The following is a description of a gene set: An abnormality of the urinary bladder. Human Gene Set: HP_ABNORMALITY_OF_THE_BLADDER studied in species Homo sapiens Abnormality of the bladder, and this is the list of marker genes: PSAP (prosaposin), GABRG2, GBE1, SYNE1, PIK3R5, CISD2, ACBD6, PDGFB, EPHB4, DNMT1, EIF4H, UBAP1, HNRNPK, SLC25A4, ZC4H2, CEP135, CHRNA2, POLG, ATXN3, ROBO1, NOTCH3, UFC1, PAX6, IFT74, EXT1 (exostosin glycosyltransferase 1), SDHD, RPL11, GJA1, DEPDC5, GALNT2, SLC35A2, CHRM3, RAC2, BBS5, MTMR14, NSD1, MAPKAPK5 (NCBI Gene Id 8550), ITGB4 (NCBI Gene Id 3691), SDHAF1, CHD4, TBP, DARS2, ATRX, BBS4 (Bardet-Biedl syndrome 4), KMT2D, HNRNPA2B1, KMT2C, NIPBL, LTBP4, SPG7, CHRNB2, KCNC3, PIGO, GTF2IRD1, BBIP1, CC2D2A, HOGA1, SMC1A, DMPK, STK11, SIX1, LIMK1, SIX5, MYLK, TP63 (tumor protein p63), TGFB1, RBM8A (RNA binding motif protein 8A), STAMBP, ERCC8, SPART, SHANK3, CCND1, CENPE (NCBI Gene Id 1062), LRRK2, LAMA3, GREB1L, SPAST, COG7, CTSH, FLVCR1, SASS6, TPP1, RETREG1 (reticulophagy regulator 1), GATA3, RARB (NCBI Gene Id 5915), RRM2B, BMP1, WWOX, ELN, HMBS, MARS2, ARNT2, SALL1, VANGL1, IFT57, HPSE2, ATL1, CFAP418, MYH11, TNFSF4, PRNP, UNC45A, CCL2, LAMC2, MFSD2A, FARS2, PANK2, METTL5, PAX2, DSE, JRK, ARL6, ATXN2, MCPH1, HACE1, VCP, MYRF, DNAJC13, FBXO7, CAPN1, NBN, IGHMBP2, PBX1, DKK1, PPOX, DNMT3A, VANGL2, SPG11 (NCBI Gene Id 80208), WNT7B, PDGFRB, SMAD3, PLXNA1, KCNT1, ZFYVE26, BBS9, IFT27, FKBP6, SCLT1, ADH1C, WFS1 (wolframin ER transmembrane glycoprotein), ZEB2 (NCBI Gene Id 9839), MAPT, CHMP2B, MCM7, COPB1, TRAF7, AP5Z1, AQP2, TRAPPC12, PUF60, ALS2, COMT, CFAP43, SEC24C, COL18A1, COL5A1, PIGA, AKT1, IFT172, KIF1A, BAP1 (BRCA1 associated deubiquitinase 1), PHC1, TTR, NF2, HSPA9, MTFMT, NEFL, ATXN10, B4GALNT1, GNB1, CIT, DNAJC30, CLIP2, SLC1A4, RBCK1, NDUFB8, KIFBP, FA2H, COL3A1, SNCA (synuclein alpha), TRPV4, PNPT1, SACS, KNL1, TRIM32, DACT1, CRH, CARMIL2, CHRNA3, DVL3, RTN2, IGF2, CDH11, TTPA, ITGA6, GIGYF2, NPHP3, TBCK, GNB2, ARX, FLNA, FAM20A, HNRNPU, HOXA13, FANCF, DSTYK, HES7, EBF3, SDHA, CPT1C, KPNA3, FUS, VPS37D, NPHP1, RYR1, STX1A, MED12, AVPR2, NAB2, CHST14, METTL27, KCNQ1, KCNQ1OT1, BBS7, MYOCD, KCNJ18, COL5A2, LAMB3, SMARCA2, SDHB, MPZ, BBS1, PPP3CA, SP110, PLOD1, FRMD5, MNX1, GABRA3, GPR101, CEP19, RNF170, SMARCE1, CCBE1, BUD23, SPOP, GRIP1, UPB1, CHCHD10, NR4A2, ERI1, ANKLE2, PRKAR1B, LZTFL1, SALL4, CEP63, ABCD1, SMO, PAH, CLCNKB, GTF2I, HLA-DQB1, ZMIZ1, HIRA, COL1A2, EFEMP2, FKBP14, CHRNA4, DBH, FMR1, SARS1, NEXMIF, LTBP1, P2RY11, COL1A1, RFC2, COL7A1, WDPCP, EIF4G1, LRIG2, KCNJ10, TTI1 (TELO2 interacting protein 1), FREM2 (FRAS1 related extracellular matrix 2), ALDH18A1, PEX11B, WASHC5, GGT1, TRPS1, AUH, EN1, SOX17, KIF5A, TBX1, BPTF, SF3B2, RALGAPA1, EIF2AK1, TERT, LMOD1, TRRAP, DPH2 (NCBI Gene Id 1802), AIP, TAF6, SBF1, ARVCF, SNCAIP, GBA2, FOXP1, EFEMP1, HLA-B, ARSA, SLC2A1, MYO1H, PAK2, COG5, LMNB1, PI4KA, GABRA1, KAT5, SLC12A3 (NCBI Gene Id 6559), KRAS, DDX6, NCAPD3, BICC1, TYROBP, ROBO2, EHMT1, CACNA1H, POT1, RAP1B, MAPKBP1, MAP3K7, ASPM, TIMM50, DPH1, CEP85L, EYA1, MBTPS2, HDAC8, MT-TT, TBL2, REEP1, KANSL1, KMT2B, PIK3CA, VPS11, CLCN6 (NCBI Gene Id 1185), SCAPER, TTC8 (tetratricopeptide repeat domain 8), POLG2, CCNQ, SMARCB1, NGF, REEP2, BRD4, MMP1, CHD7, STAT6, SUFU (SUFU negative regulator of hedgehog signaling), HAAO, FGF10, GAA, NCAPG2, CACNA1S (NCBI Gene Id 779), PLP1, NRIP1, TRAPPC10, AMFR, TWNK, CAMK2B, FOXP2, ATP7A, ZMYM2, KCND3, HCRT, CDKN1C, FANCI, POLR3A, JMJD1C, ADNP, PMP22, RREB1, MORC2, FGFR2, ATXN8OS, EIF2AK2, TBXT, EXT2, ASXL1, PINK1, APRT (NCBI Gene Id 353, adenine phosphoribosyltransferase), OTUD5, FOXF1 (forkhead box F1), NCF1, EP300, BAZ1B, ENSG00000288330, CDC45, MOG, MLXIPL, NKX2-1, CYP7B1, TBCD, FXN, AGXT, H4C9, PEX3, APC2, TAF13, TMEM270, SQSTM1, HLA-DRB1, CDK5RAP2, SLC9A6, RNF125, SLC25A13, JAG1, DLG3, ERLIN2, FGFR3, POR (NCBI Gene Id 96440), CACNA1G, DDHD2, CEP290, RASA1, SLC20A2, RAD21, SLC44A1, UBE2A, GJC2, POLRMT (NCBI Gene Id 5442), PYCR2, PSMD12, CEP152, GABRB3, SPTLC1, DNM2, MYL9, NIPA1, MKKS, STUB1, BIN1, HPRT1, IKZF1, BBS10, BBS12, MKS1, TRAPPC14, ISL1, ERCC6, HPDL, FITM2, GALC (galactosylceramidase), PIGQ, SETX (senataxin), SLC5A2, ATXN1, UFD1, DCDC2, FUZ (fuzzy planar cell polarity protein), SEMA3E, NOTCH2NLC, KY, PLA2G6, TNXB, GP1BB, GFAP, ELOVL1, GBA1, SMC3, TRIO, VPS13C, NUP37, RERE, GTF2IRD2, PIGN, ZMYM3, STRA6, PRDM8, ZNF365, COQ2 (NCBI Gene Id 27235), ALG9, UMOD, ALMS1 (ALMS1 centrosome and basal body associated protein), PLEC, BNC2, AFF4, HEXB, VPS35, WNT4, RECQL4, SCN9A, HSPD1, ACER3, BBS2, FBLN5, LIG3, MED27, ACTG2, DYSF, MACF1, HS6ST2, KDM6A, ITPR1, DPH5, SH2B1, CABP4, HTRA1, SDCCAG8, HNRNPA1, CREBBP, ATP13A2, KIF14, PRMT7, RSRC1, G6PC3, MID1, NFIA, MYF6 (myogenic factor 6), ATP1A3, WARS1, STAT1, STIL, CDK6, COPB2, HPS6, RNF168, MYCN, WDR62, SIGMAR1